Given this list of marker genes Pdia3, Prf1, Hnrnpa2b1, Srm, Ly6a, Psmb10, Hsp90ab1, Cotl1 (NCBI Gene Id 72042), Hspa4, Nop58 (NCBI Gene Id 55989), Eef1g, Ly6e, Gzma, Psme2, Atp5pb, Psme1, Ran, Fam162a, Fkbp2, Eif5a (NCBI Gene Id 28059), Krtcap2, Serp1, Tubb4b, Eif4g1, Atp5mf, Hsp90aa1, Cap1, Mettl1, Septin11, Nop16, Creld2, Itpa, Dad1, Ndufa4, Sec61b, Ptma, Ranbp1, Hspa8, Arpc1b, Pdcd11, Nhp2, Hsp90b1, Srsf6, Pdia6, Mrps28, Ppa1, Atic, Bop1, Calr, Nkg7, Sell, Nme1, Manf (mesencephalic astrocyte-derived neurotrophic factor), P4hb, Bcl3, Dkc1, Tagln2, Gzmb, Mrpl52 (NCBI Gene Id 68836), Rrp1b, Nsun2, Slc25a5, Gpatch4, Vma21, Cycs (NCBI Gene Id 13063), Ncl, Sub1, Runx3, Hspe1, Sem1, Stat3, Ddx21, G3bp1, Uqcc2, Prr14l, Lpp (NCBI Gene Id 98016), Uqcrq, Ybx1, Hspa5, Chsy1, Rpn1, Ppp1r14b, Cd52, Fbl, Canx, Pfn1, Myl12a, Sdf2l1, here is a description of the gene set: Genes positively differentially expressed in cell type: NK cell upon treatment with cytokine: IL-10 in mouse lymph nodes in vivo. Cytokines mediate cell-cell communication in the immune system and represent important therapeutic targets. A myriad of studies have highlighted their central role in immune function, yet we lack a global view of the cellular responses of each immune cell type to each cytokine. To address this gap, the authors created the Immune Dictionary, a compendium of single-cell transcriptomic profiles of more than 17 immune cell types in response to each of 86 cytokines (>1,400 cytokine-cell type combinations) in mouse lymph nodes in vivo. A cytokine-centric view of the dictionary revealed that most cytokines induce highly cell-type-specific responses. For example, the inflammatory cytokine interleukin-1β induces distinct gene programmes in almost every cell type. A cell-type-centric view of the dictionary identified more than 66 cytokine-driven cellular polarization states across immune cell types, including previously uncharacterized states such as an interleukin-18-induced polyfunctional natural killer cell state. Mouse Gene Set: CUI_NK_CELL_IL10_RESPONSE_UP species: Mus musculus from publication Cui A, Huang T, Li S, Ma A, Pérez JL, Sander C, Keskin DB, Wu CJ, Fraenkel E, Hacohen N (PMID 38057668)